Given this list of marker genes HLA-DRA, HLA-DRB3, PLEKHM1, RAB39A, HLA-DRB1, STX17, RAB30, here is a description of the gene set: Human Gene Set: GOCC_AUTOLYSOSOME_MEMBRANE studied in species Homo sapiens A lipid bilayer that surrounds an autolysosome, a single-membrane-bounded vesicle in which endogenous cellular material is degraded.